Given this list of marker genes DCLRE1C, SPIN1, GTPBP6, MTFR1, RGS18, ZFP91, UHMK1, TMEM267, ACKR3, SSH1, ZBTB20, NOL8, C19orf25, MTRF1, SLC36A4, IL17RD, FOXO3B, TTC33, TMEM106B, GNB5, TMEM191A, ERLIN1, ARID4A, RAB33B, TUBD1, TAOK1, OSBPL8, MYO3B, NFAT5, CLIC3, HBB, SPATA13, PABPC1, LZTFL1, BAIAP2L1, ARAP2, ZNF140, CMKLR2, ARAP1, SPDYE6, THAP1, here is a description of the gene set: Human Gene Set: HOFT_CD4_POSITIVE_ALPHA_BETA_MEMORY_T_CELL_BCG_VACCINE_AGE_18_45YO_ID_56D_TOP_100_DEG_AFTER_IN_VITRO_RE_STIMULATION_DN Genes down-regulated in CD4-positive, alpha-beta memory T cell 56d vs 0d in adults (18-45) after exposure to BCG vaccine, time point 56D, administered ID (intradermal). Comment: top 100 most differentially expressed genes comparing Day 0 and Day 56 responses after in vitro re-stimulation with BCG-infected autologous dendritic cells from publication Hoft DF, Xia M, Zhang GL, Blazevic A, Tennant J, Kaplan C, Matuschak G, Dube TJ, Hill H, Schlesinger LS, Andersen PL, Brusic V (PMID 28853442) Protective efficacy of Bacillus Calmette-Guerin (BCG) may be affected by the methods and routes of vaccine administration. We have studied the safety and immunogenicity of oral (PO) and/or intradermal (ID) administration of BCG in healthy human subjects. No major safety concerns were detected in the 68 healthy adults vaccinated with PO and/or ID BCG. Although both PO and ID BCG could induce systemic Th1 responses capable of IFN-gamma production, ID BCG more strongly induced systemic Th1 responses. In contrast, stronger mucosal responses (TB-specific secretory IgA and bronchoalveolar lavage T cells) were induced by PO BCG vaccination. To generate preliminary data comparing the early gene signatures induced by mucosal and systemic BCG vaccination, CD4<sup>+</sup> memory T cells were isolated from subsets of BCG vaccinated subjects pre- (Day 0) and post-vaccination (Days 7 and 56), rested or stimulated with BCG infected dendritic cells, and then studied by Illumina BeadArray transcriptomal analysis. Notably, distinct gene expression profiles were identified both on Day 7 and Day 56 comparing the PO and ID BCG vaccinated groups by GSEA analysis. Future correlation analyses between specific gene expression patterns and distinct mucosal and systemic immune responses induced will be highly informative for TB vaccine development. studied in species Homo sapiens